Given this list of marker genes SLC11A2, here is a description of the gene set: part of: SLC transporter disorders studied in species Homo sapiens Reactome Pathway: Defective SLC11A2 causes hypochromic microcytic anemia, with iron overload 1 (AHMIO1) The primary site for absorption of dietary iron is the duodenum. Ferrous iron (Fe2+) is taken up from the gut lumen across the apical membranes of enterocytes and released into the portal vein circulation across basolateral membranes. The human gene SLC11A2 encodes the divalent cation transporter DCT1 (NRAMP2, Natural resistance-associated macrophage protein 2). DCT1 resides on the apical membrane of enterocytes and mediates the uptake of many metal ions, particularly ferrous iron, into these cells. Defects in SLC11A2 can cause hypochromic microcytic anemia, with iron overload 1 (AHMIO1; MIM:206100), a blood disorder characterised by high serum iron, large hepatic iron deposition, abnormal haemoglobin content in erythrocytes which are reduced in size and absence of sideroblasts and stainable bone marrow iron store.